Given this list of marker genes ASL, GGACT, CHAC2, CHAC1, ADSL, PAM, GGCT, here is a description of the gene set: Human Gene Set: GOMF_AMIDINE_LYASE_ACTIVITY studied in species Homo sapiens Catalysis of the release of amides or amidines by the cleavage of a carbon-nitrogen bond or the reverse reaction with an amide or amidine as a substrate.